The following is a description of a gene set: An increased concentration of glucose in the urine. Glycosuria studied in species Homo sapiens Human Gene Set: HP_GLYCOSURIA, and this is the list of marker genes: HNF1A, HNF1B, SLC5A1, KLF11, EHHADH, COA8, MT-TN, BLK, ABCC8, NSMCE2, KCNJ11, PBX1, SLC2A2, GATA6, HNF4A, CTNS, ETFB, SLC5A2, ATP7B, ETFDH, APPL1 (adaptor protein, phosphotyrosine interacting with PH domain and leucine zipper 1), ETFA, LMNA, ALDOB, CLCN5, PIGA, GATM, CEL (carboxyl ester lipase), PAX2, SURF1, VIPAS39, GCK, INS, TRMT5, NDUFAF6, SLC34A1, SLC16A12, FAN1, RRM2B, PDX1, PAX4, STAT3, GYS2, NEUROD1